Given this list of marker genes SCRN1, TMED10, SGSM3, LTB, ANKH (ANKH inorganic pyrophosphate transport regulator), RPL5, C22orf39, RAB14, RPL38, TRIR, AGO1, HADHA, ZNF91, PPP1R3E, NOP53, CIITA, CLLU1, TPT1, UBA52, KDM4C, RTN1, RPL4, EIF3LP3, CBX7, THEM4, RPL7, UICLM, EIF3L, WDR11, RACK1, NAP1L1, LINC00877, ST13, HLA-DPB1, ENTR1, ZMAT3, TSPAN13, RPL32, AKAP12, DCAF16, RPL7A, HLA-DOB, ZNF785, VPS51, BNC2, KDM4B, CD1C, ESYT1 (extended synaptotagmin 1), RPL10, LINC00996, GSE1, CLDND2, ZNF575 (zinc finger protein 575), TMED4, LINC02076, DENND11, ORAI3, DCANP1 (NCBI Gene Id 140947), LBH, RPL35, PKN2, PAK2, LZTFL1, RPL27, YPEL1, SEMA4B, FBL, RPL31, ARHGAP17, EEF1G, ACOX3, RPL19, EEF2K, BAZ2A, PTDSS1, BCL11A, ZBTB40, NACA, SLC25A6, TRIM27 (NCBI Gene Id 5987), EPRS1, RPL18, COMMD6, EZH1, LINC00921, UBE4B, PABPC4, SNHG10, DPH5, INTS3, RPS3, CEP126, SNAI2, PTGDR2, ITFG2, SPIB, RPL15, EIF3F, HLA-DOA, RPL13, ZMYND11, EEF2, LARGE1, DTWD1, ZNF641, ODF2, EIF2D, PID1 (phosphotyrosine interaction domain containing 1), MAPK1, YY1, IRF4, DUS2, LRP8, CLEC4C, FCRLA, FBXL17, ZNF577, DNAL1, NRCAM, RFTN1, RPS23, RPL8, TUFM, SYPL1, THAP12 (NCBI Gene Id 9137), TOP1MT, SUDS3 (SDS3 homolog, SIN3A corepressor complex component), MMGT1, ADGRE3, CMPK1, RPS5, ST6GALNAC3, PBXIP1, RPS3A, LILRA4, CD44, FCRL3, UXT, CRIP2, GDI2, RABEP2, HIF1AN, TRIT1, STMN3, RPS10, MOB3B, POLR2L, MAST3, ARHGAP9, SIRT4, CBL, HSPA1L, ATL3, C12orf57, EEF1D, ULK4, KCTD7, KMT2E, NONO, GALNT10, GID4, ZNF665 (NCBI Gene Id 79788), RPL21, VPS36, NELL2, HLA-DQB1, EFCAB13, PTOV1, RPS12, RPS18, ABHD15, CR2, GSPT2, CYBRD1, RPLP2, ZNF264, RPLP1, EEF1B2, IL16, KLRB1, SLC27A5, MRC1, DFFA, ZNF415, ZCCHC7, EIF3D, ERGIC3, RPS14, CYB561A3, FCER1A, TBC1D9, TBL1XR1, SH3BP4 (SH3 domain binding protein 4), DNAJB6, ERBIN, TTC31, ALDH1A1, DALRD3 (NCBI Gene Id 55152), here is a description of the gene set: studied in species Homo sapiens To study the transcriptional profile of patients with acute RSV or Influenza infection,children of median age 2.4 months (range 1.5-8.6) hospitalized with acute RSV and influenza virus infection were offered study enrollment after microbiologic confirmation of the diagnosis. Blood samples were collected from them within 42-72 hours of hospitalization. We excluded children with suspected or proven polymicrobial infections, with underlying chronic medical conditions (i.e congenital heart disease, renal insufficiency), with immunodeficiency, or those who received systemic steroids or other immunomodulatory therapies. The RSV cohort consisted of 51 patients with median age of 2 months (range 1.5-3.9) and the influenza cohort had 28 patients with median age of 5.5 months (range 1.4-21). Control samples were obtained from healthy children undergoing elective surgical procedures or at outpatient clinic visits. To exclude viral co-infections we performed nasopharyngeal viral cultures of all subjects. We recruited 10 control patients for the RSV cohort with median age of 6.7 months (range 5-10), and 12 control patients for the influenza cohort with median age of18.5 months (range 10.5-26). Genes up-regulated in comparison of peripheral blood mononuclear cells (PBMC) from healthy donors versus PBMCs from infanct with acute influenza infection. from publication Ioannidis I, McNally B, Willette M, Peeples ME, Chaussabel D, Durbin JE, Ramilo O, Mejias A, Flaño E (PMID 22398282) Human Gene Set: GSE34205_HEALTHY_VS_FLU_INF_INFANT_PBMC_UP